The following is a description of a gene set: Mouse Gene Set: LIN_TUMOR_ESCAPE_FROM_IMMUNE_ATTACK from publication Lin KY, Lu D, Hung CF, Peng S, Huang L, Jie C, Murillo F, Rowley J, Tsai YC, He L, Kim DJ, Jaffee E, Pardoll D, Wu TC (PMID 17308126) Immune escape is an important reason why the immune system cannot control tumor growth, but how escape variants emerge during immunotherapy remains poorly understood. Here, we identify a new mechanism of tumor immune escape using an in vivo selection strategy. We generated a highly immune-resistant cancer cell line (P3) by subjecting a susceptible cancer cell line (P0/TC-1) to multiple rounds of in vivo immune selection. Microarray analysis of P0 and P3 revealed that vascular cell adhesion molecule-1 (VCAM-1) is up-regulated in the P3-resistant variant. Retroviral transfer of VCAM-1 into P0 significantly increased its resistance against a vaccine-induced immune response. Analysis of tumors showed a dramatic decrease in the number of tumor-infiltrating cluster of differentiation 8(+) (CD8(+)) T cells in the tumors expressing VCAM-1. In vitro transwell migration assays showed that VCAM-1 can promote the migration of CD8(+) T cells through its interaction with the alpha(4)beta(1) integrin. Site-directed mutagenesis of VCAM-1 at amino acid residues required for interaction with alpha(4)beta(1) integrin completely abolished the immune resistance conferred by VCAM-1 in vivo. Surface staining showed that most renal cell carcinomas (RCC) express VCAM-1, whereas an RCC that responded to vaccination was VCAM-1 negative. These data provide evidence that tumor expression of VCAM-1 represents a new mechanism of immune evasion and has important implications for the development of immunotherapy for human RCC. studied in species Mus musculus Genes up-regulated in highly immune-resistant cancer cell line developed from a susceptible cancer using an in vivo selection strategy., and this is the list of marker genes: Mmd, Dynap, Htra1, Khdrbs3, Prl2c2, Vcam1, St3gal6, Gpr149, Tnnt2, Jag1, Pla2g7, Ackr3, Xlr, Rgs16, Nppb, Akr1c18, Il2rg, Nrp2, Gjb4, 4930447C04Rik, Chd7